Given this list of marker genes CSTB, CACNB4, SCARB2, CILK1, CLCN2, GABRD, KCNQ3, PRICKLE1, EFHC1, JRK, GABRA1 (NCBI Gene Id 2554), here is a description of the gene set: Human Gene Set: HP_MORNING_MYOCLONIC_JERKS Morning myoclonic jerks species: Homo sapiens